Given this list of marker genes GGT2P, GGT5, GGTLC1, GGT3P, CHAC1, GGTLC3, GGT7, DPEP1, CHAC2, GGT1, GGTLC2, here is a description of the gene set: Human Gene Set: GOBP_GLUTATHIONE_CATABOLIC_PROCESS species: Homo sapiens The chemical reactions and pathways resulting in the breakdown of glutathione, the tripeptide glutamylcysteinylglycine, which acts as a coenzyme for some enzymes and as an antioxidant in the protection of sulfhydryl groups in enzymes and other proteins.